The following is a description of a gene set: Human Gene Set: chr7q32 species: Homo sapiens, and this is the list of marker genes: RNU7-27P, LEP, LINC03072, LRRC4, PLXNA4, SMO, OPN1SW, TSGA13, LINC00513, RNA5SP245, LINC-PINT, CCDC136, CAPZA1P4, MESTIT1, KLF14, HILPDA, KLHDC10, MIR129-1, MIR29A, RNA5SP244, CDC26P1, SMKR1, GARIN1B, EFCAB3P1, RNY1P11, STRIP2, MKLN1, PRRT4, MIR593, TMEM209, LINC03008, ATP6V1F (ATPase H+ transporting V1 subunit F), NRF1, TNPO3, HILPDA-AS1, CPA2, TSPAN33, FLNC-AS1, ENSG00000286380, RNU1-72P, ARF5, ZC3HC1, MIR182, RPL31P36, RNA5SP242 (RNA, 5S ribosomal pseudogene 242), PODXL, NDUFB9P2, RN7SL306P, MEST, IRF5, FLJ40288, METTL2B, CPA5, RNU6-177P, SSMEM1, H4P1, IMP3P2, RN7SL81P, CEP41, GCC1, MIR335, MIR183 (NCBI Gene Id 406959), CPA1, ODCP, ENSG00000224865, CPA4, SND1-DT, MKLN1-AS, RNA5SP246 (RNA, 5S ribosomal pseudogene 246), IMPDH1, GARIN1A, ENSG00000225144, PAX4, FLNC, COPG2IT1, UBE2H-DT, SNRPGP3, SND1, RNU6-1010P, RNU7-54P (RNA, U7 small nuclear 54 pseudogene), UBE2H, CYCSP20 (NCBI Gene Id 349158), ENSG00000201009, RNA5SP243, SND1-IT1, MIR96, SPMIP1, COPG2, RBM28, TPI1P2, FSCN3, AHCYL2, CALU, CICP14, MIR29B1, EEF1B2P6, KCP